Given this list of marker genes IFIH1, VAPB, GAN, HMBS, AP4B1, TTR, BTD, REEP2, AMFR, GALC, PNPLA6, AFG3L2, TFG, TTC19, MT-ATP8, ENTPD1 (ectonucleoside triphosphate diphosphohydrolase 1), FUS, GAMT, C19orf12 (NCBI Gene Id 83636), ODC1, CYP2U1, GBA1, ATP5F1E, ATL1, CAMK2B, KIF1A, CHMP2B, UCHL1, HEPACAM, WDR48 (WD repeat domain 48), ATP5MC3, CACNA1C, FBXO7, SLC25A15, RNF170 (NCBI Gene Id 96586), LONP1, RAB3GAP2, NIPA1, ACTL6B (actin like 6B), SPTLC1, DDHD1, ADAR, L1CAM, RAB18, TSPOAP1, NFU1, DAO, PON1, TBCE, LSM11, NT5C2, STUB1, OPTN, AIFM1, NEXMIF, AP4M1 (adaptor related protein complex 4 subunit mu 1), PAX3, BCOR, ERLIN1, RNU7-1, AP4S1, VWA3B (NCBI Gene Id 200403), LAMB1, PRRT2, COQ4, SLC2A1, CYP27A1, VPS37A, GOT2, ALDH18A1, TANGO2, ACBD6, UNC13A, GLT8D1, CCNF, NEFH, NEK1, AP4E1, ARSI, SDHD, KY, CYP7B1, TOE1, ATP5F1D, COQ5, PIGA, GATAD2B, ABCD1, GFM2, WWOX, TPK1, SDHA, DNAJC19, ADGRG1, CAPN1, RNASEH2A, GJC2, SATB1 (SATB homeobox 1), CACNA1D, SPG11, UBAP1, BICD2, MTHFR, TAF15, SPART, RARS1, OPA3, VAMP1, RNASEH2B, POLG, PFN1 (profilin 1), ERCC4, REEP1, AMPD2 (adenosine monophosphate deaminase 2), COX15, SACS, ELOVL1, UBE4A, ERCC1, ERLIN2, BSCL2, HPDL, SPG21, WDR45B, ATPAF2, ARG1, ATXN10, EIF2AK1 (eukaryotic translation initiation factor 2 alpha kinase 1), OPA1, KIDINS220, MAG, SELENOI, AP5Z1, MED13L, SLC16A2, PPARGC1A, INTS8, VCP, CHCHD10, GLE1, FARS2, PI4KA, GBE1, SATB2, USP8, MARS1 (NCBI Gene Id 4141), PEX16, NEU1, CLTC, ATXN2, ASCC3, KPNA3, DDHD2, TMEM63C, ATRX, FIG4, ARX, SLC30A10 (solute carrier family 30 member 10), ERBB4, CFAP410, PEX3, HNRNPA1, SIGMAR1, RNASEH2C, SPAST, COASY, SQSTM1, ZNF668, MTPAP, B4GALNT1, ZFYVE26, ERCC8, MAN2B1, ATP13A2, DSTYK, RARS2, DARS1, MICOS13, FA2H, ATP6AP2, DNM1L, UBQLN2, TARDBP, GJA1, POLR3GL, VPS41, INPP5K, PPP1R15B, RFXANK, REPS1, MATR3, SPTAN1, ERCC6, ALG9, IDUA, PNP, WDR45, HSPD1 (NCBI Gene Id 56733), ABHD16A, KLC2, TECPR2, CNTNAP2, SDHAF1 (succinate dehydrogenase complex assembly factor 1), GFAP, ZFR, MECP2, KIF5A, POLR1A, ATP5F1A, H4C5, PLP1, CLCN4, ATP5MK, TREX1, PDHX, SLC33A1, ALS2 (NCBI Gene Id 65058), AIMP1, SAMHD1, NDUFA13, PRPH, TREM2, CCDC88C (NCBI Gene Id 57641), IBA57, WASHC5, PGAP1, ACTB, ARL6IP1, SYNE1, HACE1, FLRT1, HIKESHI, TBCD, RNF220, DCTN1 (dynactin subunit 1), PON2, FAR1, TRMT10A, LYST, MRE11, PSAP, GPT2, SDHB, SPG7, KDM5C, SOD1, EDNRB, RTN2, ABCA12, SETX, PRUNE1, ANXA11, CPT1C, ALDH3A2, STXBP1 (NCBI Gene Id 6812), MT-ATP6, TTI1, TBK1, GBA2, RAP1GDS1, CCT5, TCEAL1, SOX10, GPRC5B, SRPX2, PON3, MTRFR, SLC1A4, ANG, here is a description of the gene set: Human Gene Set: HP_LOWER_LIMB_SPASTICITY Spasticity (velocity-dependent increase in tonic stretch reflexes with increased muscle tone and hyperexcitable tendon reflexes) in the muscles of the lower limbs, hips, and pelvis. studied in species Homo sapiens Lower limb spasticity